The following is a description of a gene set: Genes predicted to be targets of miRBase v22 microRNA mmu_miR_3108_5p in miRDB v6.0 with MirTarget v4 prediction scores > 80 (high confidence targets). from publication Chen Y, Wang X (PMID 31504780) studied in species Mus musculus Mouse Gene Set: MIR_3108_5P, and this is the list of marker genes: Spats2l (spermatogenesis associated, serine-rich 2-like, NCBI Gene Id 98693), Bcl2l11, Eya4, Otud4, Zfp992, Zfp275 (zinc finger protein 275), Aff1, Dram2, Lrr1, Zfp985, Tmem71, Krt1, Vmn1r45, Plac8, Jade3, Haus6, Pknox1, Cops6, Rasal2, Dlg3, Zfp953, Arfgef2, Zbtb41, Matr3, Fam169a, Nsg1, Sntg1, Rps6ka6, Trpc7, Med18, Stat3, Vnn1, Zfp937, Zfp423, B4galt4, Zfp708, Cask, Cxxc5 (CXXC finger 5), Cplx1, Prr32, Rb1, Tab3, Galm, Runx1t1, Prkar2a (protein kinase, cAMP dependent regulatory, type II alpha), Zmynd11, Zfp976, Tcte1, Atl2, Synm, Htr2c, Ppp2cb, Tgfbr3, Impact, Eif4a2, Cldn8, Zfp605, Zfp268, Ar, Osgin2, Fbxl3, Adtrp, Hltf, Ccdc126, Rdh12, Gnai2, Prkg2, Ulk3, Ccdc43, Avl9, Adra1a, Zfp40, Trim6, Ints13, Hmbs, Enc1, Tmem132b, Ifnlr1, Mpg, Sltm, Cdc26, Prxl2a, Ptbp3, Ahr, Jade2 (jade family PHD finger 2), Mob1b, Lrp8, Fam76b (family with sequence similarity 76, member B), Rsbn1, 4930449I24Rik, Btc, Gm7694, Nova1, Xiap, Gabra4, Ro60, Mapk10 (NCBI Gene Id 319641), Klrb1f, Dido1, Dcdc2a, Htr1f, Ces1f, Adipor1, Mturn, Ppara, Rpgrip1l, Zfp113, Mbnl3, Gpr88, Phc3, Zfp987, Golga4, Gm6408, Map1a, Zfp616